The following is a description of a gene set: species: Homo sapiens Any process that stops, prevents or reduces the frequency, rate or extent of protein K63-linked ubiquitination. Human Gene Set: GOBP_NEGATIVE_REGULATION_OF_PROTEIN_K63_LINKED_UBIQUITINATION, and this is the list of marker genes: MIR138-1, CEP63, GPS2, PLAA, PARP10